The following is a description of a gene set: Genes containing one or more binding sites for (Elk4) in their promoter regions (TSS -1000,+100 bp) as identified by GTRD version 20.06 ChIP-seq harmonization. Mouse Gene Set: ELK4_TARGET_GENES species: Mus musculus from publication Yevshin I, Sharipov R, Kolmykov S, Kondrakhin Y, Kolpakov F (PMID 30445619), and this is the list of marker genes: Gm9372, Snrnp35, Icmt, Fam193b, Vmn1r207, Dnlz, Ap1m1 (adaptor-related protein complex AP-1, mu subunit 1), Rps19, 6030458C11Rik, Msh2, Gm10848, Pet100, Lca5l, Os9, Skic2 (NCBI Gene Id 57807), Ap1s3, Dusp6 (NCBI Gene Id 67603), Cox7a2l, Khdc4, Rpl27, Gm5129 (NCBI Gene Id 332993), Pi4ka, Mast3, Clhc1, Pidd1, Tada2b, Dynll1, Dnajc10, Hydin, Taf9, Ttll11 (NCBI Gene Id 99233), Stx18, Ark2n, Cdkn1a, Trp53cor1, Foxj1, Mettl17, Eif4e2, Rps12, 2310001K24Rik, Cenpn, Fbxo45, BC031181, Rfc5, Dph6, Prdm9, Dnaaf5, mt-Nd5, Rundc1, Aars2, Ing1, Ccdc157, Ssbp2, 1110018N20Rik, Gpt2, Zfp719 (NCBI Gene Id 77372), Mir7b, Fam98a, Stk36, Clcn6, Ppp1r12b, Tmem104, 1700086L19Rik, Pik3ca (phosphatidylinositol-4,5-bisphosphate 3-kinase catalytic subunit alpha, NCBI Gene Id 70742), Sec23b, Nme6, Suclg1, Racgap1, Zfp764l1, Diaph1, Abhd4, Txnl4b, Wdr46, Clta, Wdr75, Fut10, Ndufs1, Galc (galactosylceramidase), Cfap36, Armc9, Wbp2nl, Ppp1r35, Mettl3 (NCBI Gene Id 80554), Lyrm4, Nagk, Gm23130, Ywhae, Zswim6, Ech1, Rnf25, Tor1aip1, Efl1, Cdc45, Thap1, 4921507G05Rik, Zfp768 (NCBI Gene Id 260390), Cinp, Pex16, Odf2, Klhl18, Gtf3c6 (NCBI Gene Id 67371), Rpn1, Stk11ip, 1600012H06Rik, Sec23ip, Slc38a6, Gm13562, Gm10941, Cbl, Dynlt2b, Gm13067, Gm12502, 2610005L07Rik, Drosha, Zbtb17, Catsper2, Ercc6l2, Gm20732, Pofut2, Traf3ip1 (TRAF3 interacting protein 1), Ube2v2, Rabl2, Hspa9, Ehd3, Rc3h1, Fam227b, Srgap2, Clxn, Gm25541, Rpl10, Arfip2, Mocs3, Gpr137, Ranbp10, Iscu, Irf3, Clstn1, Rfx1, Slc5a6, Glb1l, Lyrm1 (NCBI Gene Id 76435), mt-Tl1, Slx4ip, Ndufs7, Aen, mt-Nd1, Notum, Exosc2, Per2, Zfp597, Gm26901, Setd4, Ak9, Mtmr10, Phtf1, Rnf24, Egr2, Zbtb43 (zinc finger and BTB domain containing 43), Gm12146, Trp53inp1, Prr14, Gm38250, Kif9, Arc, Gm10684, Ssbp1, Dhx15, Abhd10, Rpl13a, Sart3, Plin5 (perilipin 5), Zfp715, 4921511E07Rik, Haus8, Zfp689 (zinc finger protein 689), Tbc1d17, Cops6, Cycs, Pex7, Msh3, Rxylt1, Nfkbil1, Mir132 (NCBI Gene Id 387150), Zfp384, Ncoa7 (NCBI Gene Id 211329), Sdf4 (NCBI Gene Id 20318), Ufsp2, Klc1, Tmtc3, Trmt12, Dnm3, Gm13783, Smn1, Oxa1l, Nr4a1, Tab3, Ccdc96, Prorp, Cuedc2, Pon3, Ube2o, Ebna1bp2, Arid3b, Sult1b1, Ccdc28a, Sde2, Uba52, 1810024B03Rik, Polr2i, 3110082I17Rik, Aip, Ubr4, Mpdu1, 4930524O07Rik, Mfsd13a, Egr1, Cfap96, Eapp, Slc2a9, Cetn2, Large2, Nr1h3, Tppp3, Kcnb1, Sult4a1, Ddit4 (DNA-damage-inducible transcript 4), Adk, Inka2, Laptm5, Smim43, Cul4a, Atf6, Micos13, Ribc1, Hsp90aa1, Cfap20, Nabp2, Mideas, Itln1, Tmem131, Fam131a (NCBI Gene Id 78408), Pds5a, Hspd1, Plod3, Actr8, Chmp6 (charged multivesicular body protein 6), Rbbp5, Gm13228, Acp2, Jam3, Stk16 (serine/threonine kinase 16), Ccdc34, Rps6kb1, B4galt3, Trappc2b, Zfp882, Duxf1, Rae1, Stxbp4, Chmp2b, Zfp764, Gm13421 (NCBI Gene Id 105244102), Smc1a, Gm1720, Mok, Capzb, mt-Tp, Lrr1, Micos10, Nudcd2, Wfdc3, Zfp750, Dhx38, Stk38, Gins1, Slc25a44, Mib2, E2f2, Cdk5rap2, Saxo2, Irag1, Gm5067, Fez1, Tmem209, Camkmt, Tmem221, Slc17a5, Psmb5, Zfp661, Rps27a, Vps16, Spata31e2, Gm43578, Lrrc75b, Chfr, Gm1401, Gm25939, Ippk, Vars1, Slc22a14, Dnajb12, Syt5, Cfap251, Eftud2, Adam5, Dalrd3, Thnsl1, Get4, Zfp563, Oasl1, Erh, Parg, Rer1, Ciapin1, Cyp4f16, Pdia3, Ap4e1, Col26a1 (collagen, type XXVI, alpha 1), Wrap53, 4930417H01Rik, Dnai2, 2410004P03Rik, Vdac2, Dpcd, Klhdc4, Tmem101, Septin7, Gm13728, Actr10, Coq9, Cstpp1, Xrcc1, Gar1, Gm35025, Ccdc115, 6030468B19Rik, Stk40, Cbx5, Pierce2, Gata4, Sgpl1, Glra1, Dpm1, Mfsd2b, Lmna, Hadhb, Emg1, Ppp2r1a, Tmem247, Tmem94, mt-Tv, Acin1, Wdfy1, Zfp740, Zc3h3, Mrpl36, Tubd1, Exo1, Dnaaf1, Cradd, Cmc2, Oxld1, Ggnbp1, Mcm10, Skor1, 5430402O13Rik, Gm13270, Usp22, Dnaaf3, Naa60, Homer1, Phb2, Hat1, Sik3, 1700028B04Rik, Lrrc8a, Tmem237, Gm10827, Sf3a1, Timm23, Fxyd3, Phlda3, Agbl3, Med25, Usp21, Dync1li2 (dynein, cytoplasmic 1 light intermediate chain 2), Ift22, Cert1, Robo3, 2010110E17Rik, Chd4, Fos, Pex12, Cep290, Gm15728, Mapkapk5, Ccdc137, Rpl30, Wdr3, Rpl35a, Ptpn6, Polr2e, Trp53, Zfp408, Shld1, Cep162 (centrosomal protein 162), Csnk2a2, Clcn2, Nars1, Nudcd3, Pnisr, Zfp335os, Use1, Rhbdf2, Rsu1, Dyrk3, Pold3, Ube2v1, Bad, Cacng2, Ssmem1, Uba2, Ptbp1, Mgat1, Gba1, Dnhd1, Nup85, Gm11520, Abhd12, Sys1, Ighv8-14, Rpgrip1l, Lrriq1, Atp6v1g2, Cimap3, Zbed6 (zinc finger, BED type containing 6), Xrn2, Emc3, Dpagt1, Cox11, Dcun1d3, Mff, Dync2h1, Pi4kb, Ubxn6, Rrm1, Aimp1, Cfap57 (NCBI Gene Id 77131), Mrps18b, Cenpl, Tut7, Zdhhc16, Ipo13, Nqo1, Phc2, Tac2, Dusp18, Xab2, Lrsam1, Ndufb5, Manf, Mir6236, Pitpna, Rpl18, Nfya, Oscp1, Slx1b, Pde5a, Aurka, Fiz1 (NCBI Gene Id 23877), Pbx2, Atp6v0d1, Vcf2, Ap2b1, Rabggtb, Snhg15, Osbpl11, Nsmce1, 1700030J22Rik, Cplane2, Dtwd1, Ccdc158, Enkur, Srfbp1, Celsr3, N4bp1, Cdin1, Nsun2, Alkbh3 (NCBI Gene Id 73573), Tor1a, Hspe1, Prdm6, Papolg, Aftph, Ddias, Ap2a1, Ahcyl1, Fam98b, Creld2, Cenpu, Tex50, Ddx31, mt-Ts2, Tmx4, Rnf169, Gm26504, Shmt1, Ppp1r16a, Serpinb6d, Rpl12, Pagr1a, Vamp4, Foxf1, Tm9sf4, 2810402E24Rik (NCBI Gene Id 66465), Map2k5, Cfap298, mt-Th, Kat7 (K(lysine) acetyltransferase 7), Etfrf1, Mrpl18, Dhx9, Ndc1, Zfp598, Mcmbp, Snord45c, Ap3m1, 1700041G16Rik, Gm27211, Ccdc113, Tspyl2, Ing4, Ckap2, Fanci, Txnip, Tbcel, Mgme1, Zzef1, Cep250, Dedd, Imp4, Ccdc103, Map6, Maea, Gusb, Shoc2, Rtca, Eif1-ps3, Map3k14, Dcaf6 (DDB1 and CUL4 associated factor 6), Hoxa7, Wdr90, Slc20a1, mt-Tl2, D2hgdh, Mir6906, Mir92b, Orai3, Chmp3, 6030442K20Rik, Lca5, 1700028N14Rik, Yeats2, Poll, Pced1a, Kansl1, Kifbp (kinesin family binding protein), Muc2, Hc, Scrt1, Trub2, Katnb1, Thap3, Rfx3, mt-Rnr2, Ist1, Ubc, Igsf9, Bbs1, Rev1, Lig4, Mkks, Zbtb11, Far2os1, Miga1, Tcp1, Lrrc28, Eef1b2, Pkp2, Hacd2, Hadha, Ccdc13, Arhgap29, Pkig, Spata31d1e (NCBI Gene Id 74224), Polr2h, Fuz, R74862, Ccdc25, Mul1, Azin2, Szrd1, Bbs5, Gm10535, Btg2, Cyb5d2 (NCBI Gene Id 192986), Gm15441, C9orf72, 1810012K08Rik, Gprin1, Coq4, Rps27l, Fsip1, Tpgs1, Eif2b2, Mrps5, Ufd1, Josd2, Gm8357, Ehmt1, Tbck, Dusp5, Mir707, Nsun3, G3bp2, Chordc1, C330022C24Rik, Cers1, Rph3al, Mfn1 (NCBI Gene Id 69518), Blcap, Nfe2l1, Gm10433, Mir329, Ndufs2, Unc5cl, Ccdc30, Gbp2b, Deptor, Anks3, Stamos, Dnajb6, Sppl2a (NCBI Gene Id 66552), Ghdc, Usf1, Zc3h11a, Sulf2, Eaf2, 4921536K21Rik, AW209491, Zswim1, Dyrk1a, Mob3a, Lyrm7 (LYR motif containing 7), Rpa2, Myo9b, Mmp2, Ptges3l, Zfhx3, Ppp2r3c, Stam, Snord3a, Atp5po, Slmap, Zbtb40, Wwtr1, Iqcg, Pik3r4, Dync2i2, Tomm40l, Med7, Ppil6, Gm9929, Etfbkmt, Fat1, Hbp1, Snrnp200, Snap25, Fto, Dhfr, Apobr, Mapre3, Gm6293, Alg12, Sertad3, Sft2d1, Inpp5d, Gm28500, Slc35b1, Leng8, Dnajc1, Rab18, Slc39a9, Rad17 (NCBI Gene Id 319242), Mettl15, Nopchap1, Nup35, Icam1, Zfp952 (NCBI Gene Id 319368), Pik3r2, Gm24669, Ube3c, Timm10b, Fbxo46, Lrrc8d, Bbip1, Snapc2 (NCBI Gene Id 67611), Pfdn6, Yif1a, Gm20716, Gzmk, Oard1, Acap2, Sik1, Ift57, Fam204a, Lrrc56, Kptn, Ufc1, Dnah7b, Sfi1, Cfap91, Tada3, Tmem170b, Morc3, Gm42722, Skap2, Bcl2l12 (NCBI Gene Id 75736), Dok2, Tmed10, Gm26705, Zfp365, Rlf, Psmd7, Tfb2m, Dnajc16, Per1, Gm15335, Cln3, Bbc3, Smpd2, Zfp524, Nlk-ps1, Snap29, Psrc1, Cstf1, Exoc4, Tecpr2, Shprh, Wdr53, Tdrp, Noc2l, Mrpl44, Pomgnt1, Gm12522 (NCBI Gene Id 100038453), Zfp175, Mks1, Trim32, Cyb5r4, Arpc4, Cd300e, Fig4, Msh4, Ppp1r10, Txndc15, Prkar1b, Pgk1, Ttll10, Gtf3c4, Srd5a1, Acsm2, Prepl (prolyl endopeptidase-like), Cabin1, Dnai7 (NCBI Gene Id 320662), Mtx1, Tsnaxip1, Ncdn, Sphk2, Mir7070, Stac2, Git2, Bloc1s5, Ppil3 (NCBI Gene Id 70293), Nat9, Mcl1, Rnpepl1, Trrap, Dnttip1, Ccpg1, Rcc1l, 4933427D14Rik, Fam32a, Mrpl10, Lamtor1, Ncln, Gm5786, Nelfb, Actb, Dixdc1, Cstf2t, D030047H15Rik, Bola2, Hspbp1, Gm13830, Tmem231, Fbxw2, Golgb1, Rad54l, Akt1s1, Pin1, A430005L14Rik, Cwc25, Zc3h15, Zbtb16, Cnst, Izumo4, Neurod4, Morn1, B3galt6, Scyl3, Ddhd1, D430001F17Rik, Atraid, Mmgt1, Ppp2r3d, Fndc11, Ccdc124, Arhgap11a, Tmed2, Zfp617, Poglut1, Fitm2, Vps36, Sf3a2, Slc43a1, Hsdl1, Ccng1, 3000002C10Rik, Ankrd28, Gm15564, Snx5, Fancd2, Traf4, Zfp747l1, Preb, Cage1, Usp30, Inpp4b, Nup50, Pnma1, Mus81, Nif3l1, Ak6 (NCBI Gene Id 102216272), Bdp1, Gdap2, Dars2, Nfix, Psmd12, Zbbx, Zfp958 (zinc finger protein 958), Hmmr, Sdhaf3, Fadd, Ankle2, Nsdhl, Trak2, Arhgap1, Nelfe, Zfp747, Ak1, A230103J11Rik, Sp1, Stradb, Mpc2, Zmat2, Txndc17, Rgs12, Pla2g6, E4f1, Kif1b, Cadm1, Prpsap1, Vps35l (VPS35 endosomal protein sorting factor like), Egr4, Usp31, Fendrr, Piezo1, AU040320 (NCBI Gene Id 100317), Tctn1 (NCBI Gene Id 75325), Znhit1, Caml, Ate1, Ankrd13a, Dlg4, Mir1934, Mthfr, Kif18a, Dad1, Pin4, Zfp12, Aldh1a7, Cherp, Tor1aip2, Lrrc46, Axl, Tob2, Rcan1, Selenok, Lonp2, Trmt5, A430050A11Rik